The following is a description of a gene set: from publication Chen Y, Wang X (PMID 31504780) studied in species Homo sapiens Genes predicted to be targets of miRBase v22 microRNA hsa-miR-7162-5p in miRDB v6.0 with MirTarget v4 prediction scores > 80 (high confidence targets). Human Gene Set: MIR7162_5P, and this is the list of marker genes: MGAT5, ALPK3, RTEL1, MEX3B (mex-3 RNA binding family member B), ITPRIP, APH1B, PI4K2A, SLCO3A1, ATP6V1D, SOBP, PRAMEF1 (NCBI Gene Id 93189), CERS6, GRID2, BLCAP, CTCFL, NSF, SFT2D2, ZC2HC1C (zinc finger C2HC-type containing 1C), CRLS1, SRSF2, RC3H2, ONECUT2, NKX2-8, ZNF385B (NCBI Gene Id 151126), TRABD2B, VHL, PLXDC1, ECHDC1, NETO2, JAZF1, DTNA, RHPN2, ABHD17A, VPS53, COL6A6, MYOC, PIAS4, SLMAP, PABIR3, JDP2, PIAS2, ZFAND5, PANK2, SH3GL2, ELL2, SDK1, DLST, KIAA1549, NPNT, PRAMEF13, HEXIM1, KIF21B, CREBRF, PDE1A, FAM120C, TRMT9B, DPH3P1, SFPQ, REV1, TUB, PANX1, ZNF367, CFAP410, NR2E1 (nuclear receptor subfamily 2 group E member 1), COMMD9, LBH, DIAPH1, SLC36A4, ZNG1E, DUSP5, LIN7A, MTX3, EGFLAM, ZNF440, STK32B, CTLA4, DPH3, WWOX, TNS3, SYT4, STAT4, NKIRAS2, SDK2, TET3, PPWD1, GPM6B, TFAP2A, SLC23A1, HOPX (HOP homeobox), F3, SPRED1, SULF1, TMEM164, PCNP, SFMBT1, PAX3, CREB5, JMY, BAP1, ZBTB25, PLA2G4E, GRIK3, PLEKHG7 (pleckstrin homology and RhoGEF domain containing G7), MRPS7, ZNF250, HSF2 (NCBI Gene Id 3298), CCDC14, APOLD1, IFI27L1, CEBPG, CTIF, PCDH7, PRAMEF14, SLC30A4, SEPTIN6, PRKCA, ATG2B, HAT1, OSBP2 (NCBI Gene Id 23762), DPP6, GXYLT1, KCNIP1, GAGE1, CSF1, GRIA4, CBFA2T3, ZNF26, VANGL1, TCF4, GALK2, RSU1, CADM2, AGO1, PRP4K, SLITRK3, SYT14, ABCB5, YWHAH, INKA2, SLC6A6, RIMBP2, S100B (NCBI Gene Id 6285), ATF7, CDHR3, CHRNA6, CIPC, PEG10, ASXL2, PTPRN2, FCHO2, GFOD1, ARSF, B3GNTL1, CHIC1, HCFC1, CLASP1, SIAH1, ASIC1, RPS3, KLHL3, MED23, MRPL34, PRR5L, PPM1F, ESYT3, XBP1 (NCBI Gene Id 7494), ZNF441, TRIM32, CCNH, RIMS2, PIP4K2A (NCBI Gene Id 5305), CHD2 (chromodomain helicase DNA binding protein 2), RUNX3, CCDC93, ANKFY1, GHR, KLF5, SYT1